Given this list of marker genes Grk2 (NCBI Gene Id 11557), Gria2, Homer1, Insyn2a, Picalm, Syngap1, Chrm2, Usp50, Gpsm2, Map1a (NCBI Gene Id 99114), Anks1b, Hnrnpa2b1, Zdhhc2, Gng3, Chrm3 (cholinergic receptor, muscarinic 3, cardiac), Pak6, Grn, Abhd17b, Hnrnpm, Rpl18a, Rock2, Cacng3, Rps19, Septin11, Cpeb3, Flrt3, Grm4, Epha7, Dlgap2, Camk2g, Grm7, Grin2a, Lrfn3 (NCBI Gene Id 233067), Dclk1, Snap91 (synaptosomal-associated protein 91), Dlg1, Nrcam, Stat3, Grin3a, Als2, Srgap2, Frmpd4, Mal2, Hnrnph1, Slc8a3, Ube3b, Adgra1, Slc1a1, Rims1, Eif4g2, Drd5, Epha4, Slc8a1, Ptprf, Ank3, Dmtn, Mtmr2, Slitrk5, Tnik (TRAF2 and NCK interacting kinase), C1ql2, Rplp0, Dynll2, Lzts1 (leucine zipper, putative tumor suppressor 1), Fabp5, Grin2b, Bcr, Rs1, Cap2, P2rx3, Sh3gl2, Camk2a, Camk1, C9orf72, Igsf21, Slc30a1, Fyn, Rpl12 (NCBI Gene Id 269261), Rtn1, Rps27rt, Pcbp1, Lin7a (lin-7 homolog A, crumbs cell polarity complex component), Grm1, Hspa8, Macf1, Pdlim5, Slc4a8, Adcy8, Syt12, Slc16a3, Csmd2, Il1rapl1, Adgrb3, Rgs14, Mpp2, Cript, Prkcg, Gria1, Dgcr8, Negr1, Ppp1r9a, Dst, Unc13b, Nlgn1, Baalc, Fam81a, Ptprt, Mpdz, Grip1, Calca, Pip5k1c, Rps27, Klhl17, Camk2b, Aurka (NCBI Gene Id 99385), Arc, Slc16a7, Grin2d, Gpr158, Cdk5, Bsn, Kpna2, Dnm2 (NCBI Gene Id 13430), Lrfn4, Atp7a, Shank3, Cntnap2, Elavl2, Slitrk3, Git1, Ptprs, Phb2, Rpl8, Gapdh, Rgs7bp, Kcnt1, Asic2, Nr3c2, Prr12, Camk2d, Kcna4, Napepld, Pick1, Grik2, Grin3b, Ctnnd2, Robo2, Lrfn5, Plxna4, Prkcz, Rapgef4, Vdac1, Gpr50, Vhl (NCBI Gene Id 22346), Dapk1, Srcin1, Nefm, Homer3, Grk3, Tnr, Cast, Hspb1, Adora1 (NCBI Gene Id 98749), Slc8a2, Arf1, Ppp3r1, Syn3, Adra2c, Numb, Hnrnph2, Casp3, Igsf9, Tacc3, Atp2b2, Cnksr2, Lrrc4b, Arhgap32, Rbmx, Ppp1r9b, Lrfn1, Cnih2, Erc1, Rps13, Ptk2b, Asic1, Exoc4, Igsf9b, Rtn3, Shank1, Rpl6, Rpl10a, Dtnbp1, Lrrtm3, Olfm2, Dvl1, Rps18, Itgb1, Rps6kc1, Adra2a, Kalrn, Lrp4, Dgkb (diacylglycerol kinase, beta), Efnb2, Ablim1, Crtac1, Insyn1, Prrt2, Cacna1c, Ywhaz, Cit, Nrg1, Chrna7 (NCBI Gene Id 11441), Nefh, Mgll, Mapk1, Shisa9, Elfn2, Pja2, Spock1, Lin7b, Rogdi, Dlg4, C1ql1, Slc39a3, Inpp4a, Sharpin, Rnf10, Atp1a3, Chrm4, Arhgef9, Shisa6, Tanc2, Iqsec2, Syt11, Abhd17a, Chmp2b, Efnb3, Dbn1, Abi3bp, Sigmar1, Sh3gl3, Ntsr1, Ngfr, Gabra6, Dnm3, Prrt1, Fgf22, Pacsin1, Gap43, Dnajb1, Pak2, Nrxn1, Syp, Arhgef2, C1ql3, Sort1, Akap7, Rnf19a, Calb1 (NCBI Gene Id 12307), Gria4, Atp1a1, Rab8a, Tmem240, Cd200, Dmd, Ank2, Nsg2, Sipa1l1, Ctnnb1, Shisa7 (shisa family member 7), Gapdhrt, Lrrtm4, Pde4b, Cacng7, Tanc1, Cpeb4, Zdhhc15, Ywhah, Snap47, Adcy1 (adenylate cyclase 1), Hnrnpa3, Grin2c, Gper1, Slitrk1, Prr7, Cabp1, Rpl30, Neto1, Anp32e, Neto2, Bdnf, Drd3, Gopc, Adora2a, Dpysl2, Vti1a, Pclo, Psd3, Hip1r, Sorcs2, Erbb4, Brsk1, Pcbp2, Penk, Abhd17c, Plcb4, Add2, Mapk10, Pdyn, Shisa8, Samd14, Dlgap3, Dlg2, Pak3, Olfm1, Ctnnd1, Notch1, Prickle2, Elfn1, Ryk, Lnx1, Rpl23, Grid1, Map2k1 (mitogen-activated protein kinase kinase 1), Ctnna2, Cacng8, Pura, Prnp, Dlg5, Plxnc1, Sorcs3, Clstn2, Arfgef2, Grm3, Dnajc6, Abi1, Hnrnpd, Disc1, Grik1, Lrp1, Bmpr2, Lrrc4c, Eif3a, Chrm1, Myo6, Kcnab2, Abl1, Rps3, Tsc2, Drp2, Cfl1, Syt9, Mdm2, Grip2, Mir99a, Pdpk1, Gphn, Lrrtm2, Shank2, Prickle1, Iqsec3, Map4, Adgrb1, Synpr, Cdh9, Arhgap44, Nlgn4l, Rtn2, Capzb, Mapt, Nck2 (non-catalytic region of tyrosine kinase adaptor protein 2), Add3, Rheb, Grik5, Gapdhrt2, Psd, Cpeb1, Grid2, Dgkz, Map3k7, Dbnl, Slc6a9, Mkln1, Amot, Sos1, Dlgap1, Dcc, Sema4f (sema domain, immunoglobulin domain (Ig), TM domain, and short cytoplasmic domain), Arhgap33, Stx1a, Magi2 (NCBI Gene Id 50791), P2ry1, Vangl2, Kcnk2, Lin7c, Wwc1, Sema4c, Chmp4b, Rps25, Kcnh1, Map2, Ina, Phb1, Baiap2, Grik4, Tmem108, Nectin1, Scn8a, Lrrc7, Grid2ip (glutamate receptor, ionotropic, delta 2 (Grid2) interacting protein 1), Drosha, Cacng4, Synpo, Cacng5, Ephb2, Ncs1, Arfgap1, Rusc1, Bace1, Akap9, Sh3gl1, Crtc1, Sumo2, Fmr1, Rpl7, Nptn, Fbxo45, Nr3c1, Cadm1, Lzts3, Syt1, Epb41l1, Pten, Prkn, Celsr3, Abi3, Nsmf, Dnm1l, Scrib, Sh2d5, Grik3, Gsk3b, Neo1, Homer2, Afdn, Rpl14, Bnip3, Neurl1a, Mir132, Egln1, Rtn4, Igsf11, Gsg1l, Trappc4, Dgki, Mib1, Plppr4, Tsc1, Palm, Epb41l3, Cdk5r1, Adam22, Ogt, Lrfn2, Dtnb, Nos1, Cdkl5, Grm5, Rps14, Syndig1, Pak1, Sh3kbp1, Kpna1, Adam10, Snx1, Syn1, Syn2, Prkar1b, Nectin3, Mapk8ip2, Pkp4, Sema4b, Eef2k, Tamalin, Clstn3, Crhr1, Ptprd, Rpl38, Gria3, Mir134, Dagla, Atp1b2, Sema3a, Mink1, Itpr1, Usp8 (NCBI Gene Id 99418), Slc30a3, Ptprz1, Tiam1, Vps35, Rpl4, Chd4 (NCBI Gene Id 77403), Ntrk2, Syt7, Actn2, Eps8, Rpl5 (NCBI Gene Id 19983), Plekha5, Lrrc4, Rnf112, Sptbn1, Akap5, Grin1, Ptpro, Add1 (NCBI Gene Id 11518), Stxbp5, Lrp8, Camk2n1, Gnai2, Ddx3x, Oprd1, Map1b, Itga8, Dlg3, Rgs9, Clstn1, Eif3e, Cacng2, Dicer1, Abr, Iqsec1, here is a description of the gene set: studied in species Mus musculus A synapse in which pre and post-synaptic cells are neurons. Mouse Gene Set: GOCC_NEURON_TO_NEURON_SYNAPSE